Given this list of marker genes TMEM175, PSME2, DCTN6, HDAC1 (NCBI Gene Id 3065), DHX16, PBX2, NFYA, TRAPPC2B, TM9SF1, TYW1, MED8, TP53BP1, MLLT11, CENPO, BRD7, APBB3, PARP1, GFM2, SIKE1, E2F6, SSU72, CIITA, STING1, ANAPC16, NAGK, LATS2, COQ5, GNPDA1, RASSF2 (NCBI Gene Id 9770), AIP, EIF3C (NCBI Gene Id 8663), TNFRSF13C (TNF receptor superfamily member 13C), THYN1, ASH2L, TBC1D17, TSTD2, GBA2, COMT, ITGAL, RNF181, PPCS, MLX, SEC11A, XPC, ARID3B, ABCF3, STK16, NBEAL2, TXNDC12, MSH2, OSTC, CEBPG, STAT5B, COMMD7, HIKESHI, EEF1AKMT1, TAFAZZIN, GMIP, TMEM126A, RNF41, GOLM1, NUDT7, NCBP2, TFB1M, PDE6D, TNF, P3H1, FDFT1, TMEM230, MTMR4, C2orf42, POLR2G, MED20, POLG (NCBI Gene Id 5428), CDK16, RALBP1, LIMD1, IRF4, SLC35B4, UCKL1, RER1, CSNK1A1, PLPBP, PRMT2 (NCBI Gene Id 3275), ZMYND8, CREBZF, SURF1, CHID1, CASP9, MRPL18, MMAA, CHCHD1, CXorf38, PLXDC1, TAPBPL (NCBI Gene Id 55080), SLC4A2, NCF1, RNF25, MRFAP1L1, IGF2R, ZDHHC16, ATF7IP, TAF12 (TATA-box binding protein associated factor 12), LTA4H, PDZD11, RFTN2, RBBP7, PIGC, EXOC8, TMEM129, BST1, NGRN, NDUFAF5, KIF20A, YWHAH, KLC1, FOXRED1, PTPN6, ICAM2 (NCBI Gene Id 3384), NUDT5, CAMK2G, EPRS1, DIP2B, CTSZ, TMEM9B, FOXK2, SFI1, GON4L, NLK, OSBP, PSMD13, NDE1, TLX1, IL16, ATP6V0A2, FAM120B, ENO2, CACNB3, SYK, SKI, NARF (NCBI Gene Id 26502), GMPR2, GLRB, ENTR1, AAGAB, GDPD3, LZTR1, MTO1, ZBTB14, CPT2, TYK2, MRPL42, C5orf22, RAD1, ACTR8, BNIP1, HNRNPUL2, AGRN, NAB2, PLCB3, CYBC1, RREB1, PCSK7, SEC14L1, DAP3, STX2, PPIL2 (NCBI Gene Id 23759), MAST3, VPS29, DENND2D, PRKAG2, MRE11, ZNF740, UBE4B, RTN3, CYB5R1, FAM32A, SEPTIN4, ZFYVE21, FASTKD5, TTC13, REXO5, CDC23, PSME1, SSTR1, OSBPL2, MAVS, BCS1L, UBQLN1, NMT1, OVCA2, AP1G2, CIAO1 (cytosolic iron-sulfur assembly component 1), LIN37, NLRP3, NPRL2, YY1, CFB, VPS26C, DNAJC9, here is a description of the gene set: studied in species Homo sapiens Genes down-regulated in macrophages with IL10 knockout in response to 10 min treatment by: LPS versus LPS and IL10. Human Gene Set: GSE9509_LPS_VS_LPS_AND_IL10_STIM_IL10_KO_MACROPHAGE_10MIN_DN IL-10 regulates anti-inflammatory signaling via the activation of STAT3, which in turn controls the induction of a gene expression program whose products execute inhibitory effects on pro-inflammatory mediator production. Here we show that IL-10 induces the expression of an ETS family transcriptional repressor, ETV3 and a helicase family co-repressor, SBNO2 (Strawberry notch homolog 2) in mouse and human macrophages. IL-10-mediated induction of ETV3 and SBNO2 expression was dependent upon both STAT3, and co-stimulus through the TLR pathway. We also observed that ETV3 expression was strongly induced by the STAT3 pathway induced by IL-10 but not STAT3 signaling activated by IL-6, which cannot activate the anti-inflammatory signaling pathway. ETV3 and SBNO2 specifically repressed NF-kB-mediated transcription and can physically interact. Collectively our data suggest that ETV3 and SBNO2 are components of the pathways that contribute to the downstream anti-inflammatory effects of IL-10. We compared expression profiles of macrophages isolated from IL-10 -/- mice. Macrophages were treated with either LPS or LPS plus IL-10. Treatment times were 10, 20 and 30 minutes. from publication El Kasmi KC, Smith AM, Williams L, Neale G, Panopoulos AD, Watowich SS, Häcker H, Foxwell BM, Murray PJ (PMID 18025162)